The following is a description of a gene set: Human Gene Set: WP_IDO_METABOLIC_PATHWAY IDO metabolic pathway species: Homo sapiens, and this is the list of marker genes: GOT2, KYAT3, IFNG (NCBI Gene Id 3458), KMO, KYAT1 (NCBI Gene Id 883), IDO1, IDO2, TNF, KYNU, AADAT, TDO2